Given this list of marker genes FAM234B, DEXI (NCBI Gene Id 28955), GID8, ITPRIPL2, TXN, AJUBA (ajuba LIM protein), ANGPTL4 (angiopoietin like 4), IFNGR2, CSF2RB, FAM111A, DNAAF5, KCNE3, MRPL3, MYB, ZXDB, SLC25A32, MDM4, ZDHHC7, RABGAP1, HCFC1, TPRG1L, ABR, HARS2, KHDRBS1, EI24, ZNF362, PTCD2, DIPK1A, NDUFAF7, TTC39C, FASTKD5, ZBTB45, MDN1, OTUD6B, FASTKD3, KBTBD8, RHEBL1, USP46, DDHD2, XXYLT1, PRMT3, HSD17B4, CCDC6, PURG, LRRC14, CX3CL1, COIL, AGFG1, ITPA, GMPPB, C11orf24, RPS6KA5, SDHA, SMUG1, UBXN8, SLC20A2, FAM8A1, PELO, AGBL3, MAPK14 (mitogen-activated protein kinase 14), PPRC1, EIF4A1, NOL11, DCSTAMP, EMC6, CBX6, RPP14, KDM1B, PPP1R12A, NUS1, TRIM44, TIRAP, CLNS1A, SLC38A1, GSG1, PMS2, SLC39A1, RIC8B, TOE1, DCAF12, SS18, SMIM12, TACC1, HJURP, BMF, ADORA2B, MRPL51, ERI2, GABPB2, PPAT, VIRMA, RIOX2, VPS13C, MIEF1, FAM217B, NAA15, NUMA1, MFSD5, FASTKD1, SMARCAD1, TNKS, TTPAL, POT1, HAPSTR1, PXN, CORO1C, NRROS, CCAR1, ZNF574 (NCBI Gene Id 64763), MKNK2, TIMD4, DLST, SLC35A1, CBL, ENC1, PHOSPHO2, MMACHC (NCBI Gene Id 25974), ACTG1, UBQLN1, CTTNBP2NL, EIF4G3, KMT2E, C2orf68, RGS12, SLC25A46, SPRTN, KCNK6, MOCS3, TMEM80, NEURL1B, ANXA11, GAS2L1, SH3PXD2B, MED7, ZBTB26, BRAT1, CCP110, FTH1 (NCBI Gene Id 92182), IMMT, GUSB, AHCYL1, WDR81, VPS37A, WDR36, DUSP6, TRRAP, EZH1, KLHL21, SBK1, OTUD7B, EIF3E, POLR3G, TAL1, H2AX, KDM2B, GID4, TMEM9B, ZC3HAV1L, WDR13, TSNAX, SLC25A11, HOOK3, AP4B1, HGSNAT, TIAM1, LIPT2, LRRC59, NSFL1C, MAP2K4, NIBAN2, NFATC2, TNIP2, MMD, CCND1, NT5C2, SNRK, ALG10, EPS15L1, INTS5, BEND4, STARD7, SLC29A3, ANO6, E2F8, PDS5B (NCBI Gene Id 80197), MXD4, SPATA13, CD81, MECP2, FMNL2, TXLNA, CLDN12, LSM14A, KANK2, SMCR8, MEAK7, EXO5 (exonuclease 5), RBM5, HEBP1, PTPN3, here is a description of the gene set: Neutrophils play critical roles in modulating the immune response. However, neutrophils have a short circulating half life, are readily stimulated in vitro, and have low levels of cellular mRNA when compared to other blood leukocyte populations. All of these factors have made it difficult to evaluate neutrophils from clinical populations for molecular and functional studies. Here we present a robust methodology for rapidly isolating neutrophils directly from whole blood and develop ‘on- chip’ processing for mRNA and protein isolation for genomics and proteomics. We validate this device with an ex vivo stimulation experiment and demonstrate the ability of the device to discriminate subtle differences in the genomic and proteomic response of peripheral blood neutrophils to direct and indirect stimulation. Lastly, we implement this tool as part of a near patient blood processing system within a multi-center clinical study of the immune response to severe trauma and burn injury and demonstrate that this technique is easy to use by nurses and technical staff yielding excellent quality and sufficient quantity of mRNA for sensitive genomic readout of the host response to injury Human Gene Set: GSE22103_UNSTIM_VS_GMCSF_AND_IFNG_STIM_NEUTROPHIL_UP species: Homo sapiens from publication Kotz KT, Xiao W, Miller-Graziano C, Qian WJ, Russom A, Warner EA, Moldawer LL, De A, Bankey PE, Petritis BO, Camp DG 2nd, Rosenbach AE, Goverman J, Fagan SP, Brownstein BH, Irimia D, Xu W, Wilhelmy J, Mindrinos MN, Smith RD, Davis RW, Tompkins RG, Toner M, Inflammation and the Host Response to Injury Collaborative Research Program (PMID 20802500) Genes up-regulated in neutrophils: untreated versus stimulated by CSF2 and IFNG.